The following is a description of a gene set: Human Gene Set: ZC3H11A_TARGET_GENES from publication Yevshin I, Sharipov R, Kolmykov S, Kondrakhin Y, Kolpakov F (PMID 30445619) Genes containing one or more binding sites for (ZC3H11A) in their promoter regions (TSS -1000,+100 bp) as identified by GTRD version 20.06 ChIP-seq harmonization. species: Homo sapiens, and this is the list of marker genes: FBXO28, TMEM82, B4GALT7, RAB18, MIR4999, YJU2, MLEC, PHKA2, CENPP, GLT8D1, MPHOSPH10, ZNF675, METTL6, CA11, SUGT1P4-STRA6LP, KMT2B, EIF4G2, ATP6V1G2-DDX39B, PARP1, THEM4, DOK1, GXYLT2, MKRN2, EIF1AD, CTNNA2 (NCBI Gene Id 1496), SNRNP200, BORCS6, RTEL1, SRRT, KIF15, CSTF2T, ZC3H4, SSU72, PLA2G4C, NR1H3, PXT1, PTP4A2P1, RNU6-1340P, COL25A1, MAP4K5, C12orf76, RRN3P1, DPY19L4, FBXO2, DRG2, RSBN1, B3GALT9, KDM3B, MRPL21, SAFB, HMGA1, TGFB1, CDK11A, WDR24, LINC00581, NKAP, RNVU1-15, C8G, NCKAP1L, NR1H2, GDI2, WDR45B, GEMIN4, C6orf141, MAPK8IP3, RNU6-85P, KPNB1-DT, ARL6IP4, ODAD3, HEMK1, SLC22A11, C18orf21, NPLOC4, PSCA, GLG1, SNX17, SH2B1, SLC27A5, SSU72-AS1, GP6, CSTPP1, C11orf68, RNU6-166P, ZNF768, TOR1AIP1, GRPEL2, SNAP29, DDIT4, JRK, FAAP20, RFXANK, DNAJC24, OAZ1, AGK, ZNF280D, C10orf88, CDC42, MAZ, HERC3, CCDC65, NYAP1, KAT8, SLC20A2, CLDN23, CYTH2, CHMP2A, ISG15, TRMT61B, TPI1P2, DDIT3, SUGCT, C9orf163 (NCBI Gene Id 158055), ITGAL-AS1, TDP2, OR1X5P, C3orf38, AIG1, GNL3L, TFE3, ILF3, GTF3C3, ENSG00000243004, CROCCP3, UBE2H, SENP1, ZMPSTE24, IFT56, KIAA1143, RNVU1-6, MED15, ZC3H3, RPL36AP36, PHF8, MRPL16, LPGAT1, CCDC12, TMEM41A, STX16-NPEPL1, RTTN, MKRN3, GOLGA3, ZNF165, CNEP1R1, CDC16, HIRA, PPM1F, CDK5RAP3, DNAJC25-GNG10, PLAC9, OR1X1P, TMEM87B, TMEM267, CNBP, BECN1, MAFA, STX18-AS1, CCNB3, ELOB, BBLNP1, ADAP2, IL16, TP53BP2, GTF2H4, KIAA0586, CPSF1, GDF15, ACACA, RFX1, RNU5F-1, NUP107, SMIM19, THOC6 (NCBI Gene Id 79228), LINC01347, YAP1P1, VPS13C-DT, DHX8, MBTPS2, BRD2, HIPK1-AS1, JPX, ABCA17P, ZNF561, ERI1, GFM2, HSD3B7, DIAPH1, HCFC1R1, ZER1, NLE1, ZBTB45, PRPF38AP1, SPATA20, FAM228B, TRIAP1 (TP53 regulated inhibitor of apoptosis 1), DGCR8, CCDC69, SEMA3B, VARS1, CNOT6, PSMG3 (proteasome assembly chaperone 3), MIR6781, RPL36, PCF11, BMS1P4-AGAP5, HMGB1, DUS2 (dihydrouridine synthase 2), TRUB2, RPL37, C17orf75, WEE2-AS1, VPS9D1, SEC13, FASN, FBXW8, SCN3B, MB, ASF1B, JAZF1-AS1, SEPTIN5, EEF1A1P23, TBC1D19, LL22NC03-63E9.3, ZC3H6, ANKRD33BP7, XPNPEP3, FAU, COPS2, PDE2A, RNF216, MIR4757, FRG1-DT, CWC25 (CWC25 spliceosome associated protein homolog), LINC01149, DDR1, PTPRU, ZC3HC1, SON, NUCB1-AS1, ZNF490, R3HCC1, SSR4P1, TRADD, H3P44, EPC1, ZNF593, DTX2, RSPH3, RNF185 (ring finger protein 185), EMC10, DGAT1, TOP3B, CIAO1, MRPL58, RORA, TIGD1, SCAND1, BSCL2, MIRLET7BHG, BRAF, HYCC2, LIPA, RNU6-386P, UNC13D, AZI2, NME1-NME2, FRS3, RPL39P18, PCYT1A, DTWD1, MAP3K5, SNRPD1, TRPC4AP, CCDC106, ACP2, EDC4, UBE2Z, PSMF1, PSMG3-AS1, NFKBIL1, TAL1, SNORD48, GLRX5P2, CENPN-AS1, RPS18, YEATS2, ZNF341, HNRNPD, DCP1A, ABITRAM, MFSD11, RADIL, KPNB1, GNAZ, CEACAM21, PRRG2, SDAD1, LINC01485, FAM177A1P1, STX4, C8orf33, MITD1, YIPF2, COQ4, NUF2, BBS1, ZNF408, HECA, INTS1, FOXP1-AS1, CCDC57, SF3B6, H3P10, CLTB, MED23, CHD2, SLC37A4, ENSG00000246308, PPATP1, NPAS1, TMEM222 (NCBI Gene Id 84065), POLR3B (NCBI Gene Id 55703), ENPP3, GTF2IP12, CCDC88A, ZNF185, ATF3, TNFAIP8L1, KCTD5, ILF3-DT, COX6B1P1, MTMR9, FOS, BHLHE40, ZNF863P, NOC4L, JSRP1, MARK4, LINC01235, SLC39A13, LNCARSR, BMERB1, EXD2, RNF6, PRAME, ANTKMT, ESCO1, CLASP1, GTPBP3, API5, CSNK1A1P1, NDUFS7, PPP1R42, C2CD5-AS1, MTND1P14, NDUFC2-KCTD14, ENSG00000244137, REPS1, CD160, LPIN3, TMEM242, METTL9, SLC29A3, TSEN54, PDCD6, FBXW5, GALNT16-AS1, DHX33-DT, ALKBH4, TMEM128, SCRIB, OTUD7B, NFKBIB, BCRP2, ZDHHC4, HOMER1, PAK1, CRKL, TRIM55, DRAP1, TOR1B, MVK, MLST8, RB1CC1, RCOR3, OSGIN1, UQCC6, LYN, GGCX, CLUAP1, HMGXB3, VPS13C, ABCA3, TPTEP1, AAR2 (AAR2 splicing factor), KLHL20, NOP16, WNT8A, AP4E1, TBL3, NOSIP, CROCCP2, DDX1, ASIC1, ZMIZ1, ENSG00000200235, NDUFC2, ATF7IP, RNU7-27P, CSNK1A1, UBE2V1P4, TIGD6, EFCAB7, SRSF8CP, ILDR1 (immunoglobulin like domain containing receptor 1), LINC00929, N4BP3, MIR3190, ASS1P5 (argininosuccinate synthetase 1 pseudogene 5), PCNP, RTN4R (NCBI Gene Id 96184), RPS20, PDE2A-AS1 (PDE2A antisense RNA 1), DCDC1, EXOC7, PEMT, CDKN2AIPNL, CMKLR2-AS, GALNTL5, YWHAE, BORCS8-MEF2B, DNAJC2, EPS15, CEP95, RN7SKP175, DDX55 (DEAD-box helicase 55), CPSF4, HELQ, PPP1R37, CCDC90B, INO80B-WBP1, NOL8, LRRC37A3, RNVU1-27, SPAST, TSPAN10, RERE, NORAD, BSDC1, FAM222A, KRT18P45, OGT, MTO1, EPC1-AS1, DDX51, DDAH2, MCAT, FAM98B, ZNF276, NUDT5, CUL4AP1, OR7A17, DAGLB, ATP6V1B1-AS1, COQ10A, SIRT5, SPEG (NCBI Gene Id 729871), VPS25, HIPK1, CASP2, SMG7, IFT57P1, DNAJB13, NSUN4, ZSCAN9, GLUD1P3, RAB11B, MIR3162, AP1S3, MIR3611, GALK2, CCAR2, SLC33A1, METTL15, TMEM147, TXNRD2, KEAP1, VCL, CYP4A22-AS1, UBE2D3-AS1, COPS7B, KBTBD4, PCID2, SSBP4, FBXW2 (NCBI Gene Id 26190), ENSG00000266313, PPP1R15A, EXOSC4, NOXA1, NELFB, PPIL2, AP3S2 (adaptor related protein complex 3 subunit sigma 2), MMADHC, OR5AQ1P, GARIN5A, WDR11-DT, ACSF3, UBTF, DDX18, SHARPIN, OPA1, PSME3, SEC22B, PLEKHG5, COMMD2, RFC2, CHMP1A, STX16, REV1, PTK2B, ATPAF1 (ATP synthase mitochondrial F1 complex assembly factor 1), JARID2, CHFR (NCBI Gene Id 56732), SNHG32 (NCBI Gene Id 50854), MIR3529, TRIM15, PSMC2, PDE4A, ZBED5, ABHD12, SDC4, ISLR2, TPH2, VPS28, MRPL39, MRPS18C, SHROOM1, COMT, KCTD20, KCNH1, PLK3, ENSG00000232995, ELP1 (elongator acetyltransferase complex subunit 1), ATMIN, LINC01719, CELF2-AS2, TOMM5 (NCBI Gene Id 644560), CLK3, SSBP1, TMEM127, MRPL55, MRPL24, ZBTB21, BORCS8, NDUFB10, CUL4A, RND1, NOL12, TACO1, NFAT5, SART1, TM2D3, TVP23B, KNL1, RPL32P27, ZNF746, KIF22, MIR1205, B3GAT3 (NCBI Gene Id 26229), LRRC37A5P, NDUFAF4P1, CPNE7, ADGRL1-AS1, PPP6R1, MIR3908, ADAT2, DNAJC25, UBE2D3, MTND3P4, RIF1 (replication timing regulatory factor 1), MIR4510, SNAP25, AURKAIP1, PRKCSH, SLX9, SAE1, PVT1, PIGG, EIF2D, MRPL30, RNA5SP474, CASD1, KCNH1-IT1, NADK2, TBX6, TMEM259, ZNF561-AS1, DPM2, PYURF, ZNF74, TLCD3B, ZMYND8, CDCA7P1, USB1 (U6 snRNA biogenesis phosphodiesterase 1), SLC25A16, MRPS34 (mitochondrial ribosomal protein S34), DSTYK, MAF1, LRWD1, FEM1A, PPIA, RUNX1, BHLHE40-AS1, IFRD2, PTCD1, TRBV21-1, ZNF76, ARF1, PLA2G15, PSTK, TRDMT1, FCHO2, CYP1B1-AS1, TCF12, ST7L, INTS14, HEBP2, KMT2C, GSTCD, DMAP1, KLHL17, RNU4ATAC, EI24, SLC30A1, JOSD2, MPLKIP, ETV4, BLTP2, MORF4L1P5, NFE2L2, HTR5A, ENSG00000231119, LTK, FBXO34, AP2M1, JARID2-AS1, ENSG00000265246, RBM28, RNU4-62P, TUFM, STX18, CNBD2, ENSG00000227218, PDCD6-DT, PRPF18, GPR137, NCOA3, SLC35A3, RSPH14, CCDC90B-AS1, SAR1B, ANAPC5, RTEL1-TNFRSF6B, ZMIZ1-AS1, ZNF213-AS1, VPS13B-DT, FAM118A, DHX33, MCM5, RGS5, VPS45 (vacuolar protein sorting 45 homolog), GART, GGA3, JHY, PCLAF, GEMIN7, HNRNPD-DT, ATP6V0C, TTC1, PDE6D, SP3 (Sp3 transcription factor), SLC44A1, BEND6, PLPBP, LIX1L-AS1, BANF1, GTF2IRD1P1 (GTF2I repeat domain containing 1 pseudogene 1), LINC01898, LINC03011 (long intergenic non-protein coding RNA 3011), PMM1, TPBGL-AS1, ACOX3, COPS4, ITGB4, RNF168, GATC, FZD1, MTFMT, BANP, ARHGAP1, ADARB1, TMEM147-AS1, BMS1P4, NFE2, SDHAF3, MKNK2, SDHAF1, NDUFB3 (NADH:ubiquinone oxidoreductase subunit B3), FRA10AC1, AKAP9, CFTR, CCDC88B, PPARD, EIF2B4, SLC39A3, SLFN12, TAGAP-AS1, KRR1, SELENOH, TRIP4, RLIG1P2, HUS1, MIR3928, SNX18, ACOT13, PI4KA, SUGT1P4-STRA6LP-CCDC180, LINC00853, SSBP2, SFTA2, HES4, ST13, SPCS1, ZNF205, ZSCAN16-AS1, GNAI2, TARS2, ENSG00000202059, ASF1A (anti-silencing function 1A histone chaperone), VPS51, FAM227B, FMN2, HINT3, PCBP1-AS1, SPAG8, NBEAL2 (neurobeachin like 2), DHRS13, HNRNPA1, LINC01144 (NCBI Gene Id 400752), PLEKHG4, TATDN3, GTF3C5, QSER1, CD63-AS1, DENND1C, EAF1, SUPT5H, TIMM9, MRPL20, AQR, SF3A3, GAK (NCBI Gene Id 2580), SRSF2, IGLV1-47, LIM2-AS1, CASKIN2 (CASK interacting protein 2), TRMT112, ZNF580, FSCN1, E2F6, ALDOA, NDUFS3, ZBED5-AS1, FRG1, DIAPH1-AS1, VARS2, TRMT44, FEM1B, VPS52, USPL1, GAS8 (NCBI Gene Id 2622), MT2A, HTATSF1P2, EMC4, MORF4L1, CCNC, RAF1, MAN2C1, RBM8A, INTS12, NAPSA, ELOA-AS1, UBE2H-DT (UBE2H divergent transcript), ATP13A4, SHOC1, GABARAPL3, RRP15, AURKB, EIF4E2, COPS3, CDC123, PFKM, SMCR2, ITGB2, SMIM8, NDUFAF1, SUGT1P4, SDAD1P3, CGGBP1, ABLIM3, ENSG00000260592 (novel transcript, antisense to TMC5), TUT1, EXOSC3, NME1, TIMM29, PINK1, AMBRA1, STMN3, ERLIN2, ADRM1, ARPC3, TNRC18, RPS7 (NCBI Gene Id 6201), CFAP74, TNPO3, ZMPSTE24-DT, DUS1L, INTS5, ZSCAN12, RNF187, C6orf62, CHTOP, TRGV7, MST1P2, DGCR2, CTNNB1, SEPTIN7P14, ZNF391, MIR1538, WDR11, OLFM2, REXO4, ZNF581, ZNF180, CD63, DHTKD1, SNAP47, UTP3, ADA, TYK2, EXOSC2, RFC1, PSMD11, EME2, RBBP5, NIPBL, MRPL1, LOXL3 (lysyl oxidase like 3), JMJD4, IGHMBP2, TEFM, SPMIP10, GBA1, SAFB2 (scaffold attachment factor B2), PRDX5, NUDT8, SPATS2L, GEMIN5, PIGL, ATP6V1G2, RN7SL344P, COA6-AS1, TMEM98, HNRNPMP2, CLK1, XRCC2, BMS1, NUP214, MCEE, FAM98C, AGMAT, MIR3189, ADNP, WDR31, PANK4, SPATA33, EVA1C, VPS13D, NOL6, ZNF786, PRAMEF29P, TMEM187, ZNF554, ZCWPW2, UTP4, CACNB3, PARP12, SMG7-AS1, TEX38, KNTC1, SNHG30, TAF1C, INO80B, SIRT2, FES, FABP5P3, HCG21, GHITM, AGK-DT, HCFC1, CHFR-DT, USP30, ITGB3BP, ACER3, ARHGEF37, MRPL40, LY6G5C, EXD3, MRPL49, GDPD5, COA6, MIR548XHG, CUEDC2, TBC1D13, SYCE2, MT1X, IPO4, BICDL3P, WDR36, SRF, DDX5, NEAT1, TSPYL1, VPS13B, EEFSEC, COMTD1, TXN2, HPCAL1, ATF7-NPFF, VWA7, PFAS, MBD6, RNU6ATAC, MTERF4, DMTN, MADCAM1 (mucosal vascular addressin cell adhesion molecule 1), ZCCHC8, FBXO22, TRPM6, EP400, MRPS31, NSL1, TMEM101, RAB40C, FBXO34-AS1, PEX3, ZNF721, SBDSP1, MTHFD2L, TMEM230, MIX23, CBX5, RNVU1-34 (RNA, variant U1 small nuclear 34), YTHDF2, TMEM63A, ZNF791, LNC-LBCS, PLEKHM3, ZNF385A, SNORD54, EIF3F, RNVU1-14, TRMU, NSA2, TMEM242-DT (NCBI Gene Id 118732303), DST, SLC24A1, IFTAP, SMG8, SP7, LINC01547 (NCBI Gene Id 84537), IGF2BP2, E2F2, VPS37B, MBNL2, ARMH3, PHACTR4, GIT2, NUP54, SLC37A3, HAUS1, NUP107-DT, CFAP299, TTC4, LSM5, TRA2B (transformer 2 beta homolog), ANGEL1, STOML2, CERNA3, LINC01287